Given this list of marker genes NCK1, PPP1CA, DNAJC3, NPM1, EIF2S1, IMPACT, NCK2, EIF2AK4, EIF2AK3, PPP1R15A, PML, here is a description of the gene set: Any process that modulates the frequency, rate or extent of translation initiation, as a result of a stimulus indicating the organism is under stress. species: Homo sapiens Human Gene Set: GOBP_REGULATION_OF_TRANSLATIONAL_INITIATION_IN_RESPONSE_TO_STRESS